Given this list of marker genes Enpp1, Park7, Coro1b, Vtn, Arpc5, Nox1, Ptger4, Rhoa, Pparg, Ssh1, Agt, Smo, Camk2d, Retn, Pcsk5, Iqgap1, Ptpn1, Nr4a3, Il18, Gstp2, Ace, S100a11, S100a11-ps, Nrp1, Drd4, Dock4, Ppard, Mmp1a, Has2, Bcl2, Igfbp5, Tpm1, Il6st, Xbp1, Igfbp3, Kcnn4, Myo5a, Pak1, Stat5b, Tlr4, Postn, Src, Itga2, Mdm2, Atp7a, Adamts1, Slit2, S1pr2, Ddit3, Plxna1, Fat1 (FAT atypical cadherin 1), Myc, F3, Zfp950, Plau, Myocd, Fgf9, Serpine1, Tert (NCBI Gene Id 21752), Ddr2, Egfl7, Grb10, Abhd2, Dock7, Hdac4, Tacr1, Lpar1, Gna12, Map3k7, Apex1, Pdgfrb, P2ry6, Bmpr1a, Trib1, Mir504, Pde4d, Myh9, Ptk2, Gna13, Rps6kb1, Egr1, Rapgef4, Cyp1b1, Ndrg4, Ilk, Sorl1, Pdgfb, Prkg1, Ddr1, Ccn3, Dock5, Ager, Pdgfd, Pgr, Sema6d, Nf1, Ccn4, Mdk, Nox4, Tafa5, P2ry2, Aif1, Fga, Nfe2l2 (nuclear factor, erythroid derived 2, like 2), Pdgfa, Mir124a-1hg, Itga4, Lrp1, Foxo4, Ccl5, Adipoq, Igf1, Itgb3, Cav1 (caveolin 1, caveolae protein), Mef2c, Ppargc1a, Rapgef3, Plat, Parva, Arpc2, Tmsb4x, Gstp1, Crk, here is a description of the gene set: species: Mus musculus Mouse Gene Set: GOBP_SMOOTH_MUSCLE_CELL_MIGRATION The orderly movement of a smooth muscle cell from one site to another, often during the development of a multicellular organism.